Given this list of marker genes ACSF3, UBA1, ACSL6, ACSM4, ACSM2B, SLC27A3, DIP2A, ACSL5, ACSL1, UBA5, MOCS3, SLC27A6, ATG7, SUCLG2, AASDH, ACSL3 (acyl-CoA synthetase long chain family member 3), SLC27A2, ACSBG1, ACSM3, ACSF2, UBA2, ACSS2, ACSM2A, SLC27A4, ACSS3, ACSBG2, SAE1, SLC27A5, ACSM6, UBA7, SUCLA2, SLC27A1, AACS, ACSM5, NAE1, ACSS1, UBA6, ACSM1, SUCLG1, ACSL4, UBA3, here is a description of the gene set: Catalysis of the joining of two molecules via a carbon-sulfur bond, with the concomitant hydrolysis of the diphosphate bond in ATP or a similar triphosphate. Human Gene Set: GOMF_LIGASE_ACTIVITY_FORMING_CARBON_SULFUR_BONDS species: Homo sapiens